Given this list of marker genes Slitrk3, Nlgn2, Nrxn2, Nrxn1, Zdhhc12, here is a description of the gene set: studied in species Mus musculus The clustering process in which gephyrin molecules are localized to distinct domains in the postsynaptic density as part of postsynaptic density assembly. Gephyrin is a component of the postsynaptic protein network of inhibitory synapses. Mouse Gene Set: GOBP_GEPHYRIN_CLUSTERING_INVOLVED_IN_POSTSYNAPTIC_DENSITY_ASSEMBLY